Given this list of marker genes KCNJ10, BSND, CYP11B2, TXNRD2, CYP21A2, NR0B1, CYP11A1, MUC1, NNT, SARS2, KCNJ16, MRAP, SLC12A1, CLCNKA, SCNN1A, CYP11B1, MC2R, KCNJ1, STAR, DLG5, CLCNKB, HSD3B2, here is a description of the gene set: Human Gene Set: HP_RENAL_SALT_WASTING A high concentration of one or more electrolytes in the urine in the presence of low serum concentrations of the electrolyte(s). studied in species Homo sapiens Renal salt wasting